Given this list of marker genes EXOSC8, MAPKAPK2, EXOSC2, EXOSC9, EXOSC7, ZFP36L1, EXOSC6, DCP1A, AKT1, XRN1, EXOSC5, EXOSC4, YWHAB, DCP2 (decapping mRNA 2), DIS3, EXOSC1, EXOSC3, here is a description of the gene set: Butyrate Response Factor 1 (BRF1) binds and destabilizes mRNA Human Gene Set: REACTOME_BUTYRATE_RESPONSE_FACTOR_1_BRF1_BINDS_AND_DESTABILIZES_MRNA studied in species Homo sapiens